The following is a description of a gene set: Nitric oxide (NO) produced by macrophages (MØs) is toxic to both host tissues and invading pathogens and its regulation is therefore essential to suppress host cytotoxicity. MØ arginase 1 (Arg1) inhibits NO production by competing with NO synthases for arginine, the common substrate of NO synthases and arginases. Two signal transduction pathways control Arg1 expression in MØs. First, a MyD88-dependent pathway induces Arg1 in intracellular infections, while a second Stat6-dependent pathway is required for Arg1 expression in alternativelyactivated MØs. We found that mycobacteria-infected MØs produce soluble factors that induce Arg1 in an autocrine-paracrine manner via Stat3. We identify these factors as IL-6, IL-10 and GCSF. We further establish that Arg1 expression is controlled by the MyD88-dependent production of IL-6, IL-10 and G-CSF rather than cell intrinsic MyD88 signaling to Arg1. Our data reveal the MyD88-dependent pathway of Arg1induction following BCG infection requires Stat3 activation and may result in the development of an immunosuppressive niche in granulomas due to the induced Arg1 production in surrounding uninfected MØs Human Gene Set: GSE22935_UNSTIM_VS_24H_MBOVIS_BCG_STIM_MACROPHAGE_DN from publication Qualls JE, Neale G, Smith AM, Koo MS, DeFreitas AA, Zhang H, Kaplan G, Watowich SS, Murray PJ (PMID 20716764) Genes down-regulated in macrophages: untreated versus 24h after M. bovis BCG infection. studied in species Homo sapiens, and this is the list of marker genes: NFIL3, CASP4, ZNF260, ACYP1, LRRTM1, NKX2-5, CAMKK2, SGCB, LIN28A, EFR3A, ILRUN, NAB1, ANKRD44, VPS54, LIN9, TBK1, TBC1D1, E2F3, CSF1, ZRSR2, NT5C3A, CA13, DNAJA1, PHLDA1, PRRX1, FBXL3, RFX5, STARD3, KLF3 (NCBI Gene Id 51274), NOC4L, PARP9, HOXB7, CD14, RNF14, ITGB1, SF1, NPAS1, TBC1D13, ATAD2B, MAFF, FAM133B, LRRC4, TOMM70, RNF214, MMP13, RAB38, STAP2, PIM1, HCAR2, COLEC12, KREMEN1, HIVEP2, NAT2, KLRC1, IRF5, AMOTL2, NTF3, DPP6, TREM1, TBC1D23, OGFR, RAP1B, GATAD2A, ODF4, DNAJB12, PHLDB1, MELK, ZNG1B, XRN2, PROCR, TENT2, GTF2F2, PPP2R5A, ADAR, PHTF2, AQP3, MKKS, SLC44A2, ARHGDIG, RRP7A, FBXW11, TMEM116, U2SURP, SPRYD7, CLN3, MPHOSPH6, RNF19B, UBR4, RAB13, TLR3, SLC7A8, CABP2, IRF2, PLAAT3, CCL2, PDLIM1, OAF, AGPAT3 (NCBI Gene Id 83745), MPP1, CD38, APPBP2, GCM1, FIP1L1, GTF2A1, LMO4, ZNRF1, CHST15, TAC1, ARMH4, SELE, ADRA1B, MTMR6, HCK, IGF1, MAGT1, MSN, OTUB1, IFI35, JUNB, DDIT4L, CACNA1A, PRKD3, AIG1, ETS1, ARR3, RCN1, SLC10A6, ELF1, SLC6A3, RNF135, PLOD3 (procollagen-lysine,2-oxoglutarate 5-dioxygenase 3), SPRED1, BRAF, GABRA2, NR3C1, DLAT (dihydrolipoamide S-acetyltransferase), GABRB1, PRKRIP1, EIF4E, CHUK, ZNF503, CHI3L1, IFIH1, NUBP1, BIRC3, ARL4A, MAPK6, NOCT, SP110, MFSD6L, NSMAF, CSRP1, ZC3H15, SERTAD2, MED14, RAMP2, SLC17A3, ADAMDEC1, CDV3, TMEM39A, SDSL, C1R, KARS1, ANGPTL8, FTH1, SNX18 (NCBI Gene Id 112574), SERPINA6, CCL22, IL1B, RPE, USB1, HSPA1A, SGMS1, C16orf87, LPAR4, PTPRT, FAM3B, APAF1, BTBD17, SEC14L4, KLHL13, KCNJ5, CHAC2, NXF2, ZNF281, CMTR1, PCDH20, CPA2, DEXI, IL10, TAX1BP1, LATS1, PDE4A, TCF4, TPX2, KCNMB1, CD83, PRKN, MND1, ITGB4